Given this list of marker genes Klf4, Ahr, Kat8, Jak2, Slc37a4, Ercc1, Myo1e, here is a description of the gene set: The stages of blood cell formation that take place after completion of embryonic development. Mouse Gene Set: GOBP_POST_EMBRYONIC_HEMOPOIESIS species: Mus musculus